Given this list of marker genes ENSG00000310416, ENSG00000298316, ENSG00000301473, FRG1GP, RNA5-8S5, FRG1FP, ZNF73P, ACTR3BP7, here is a description of the gene set: Human Gene Set: chr22p11 species: Homo sapiens